Given this list of marker genes ZEB1, NUFIP2, CDY1, CCDC83 (NCBI Gene Id 220047), ACRV1, NLRP2B, RGS21, NDRG1, CCNK, MMP12, TSHZ2, FBRS, ZCCHC9, ERI1, PPM1E, OTUD7B, PCBP2, RBM25 (NCBI Gene Id 58517), DIO2, IPMK, FGD4, DOP1A, ZNF566, CYP7B1, AKT1S1, CDY1B, HSPA9, ZG16, LINGO2, HSD11B2, GOLGA7, MTMR4, FAM131A, FSD2, APOL6, PCGF5, PCBP1, AFF3, C16orf54, PAPOLG, KPNA4, MORF4L1, UNC45B, TMEM167A, PRLR, DNM3 (NCBI Gene Id 26052), KBTBD2, HSPH1, SMC4, MARCHF7, WDR55, CYP20A1, DCP1A, ZC3HAV1, ADGRF5, GREM2, PRR11, ANKS1A, EEF1E1, here is a description of the gene set: Genes predicted to be targets of miRBase v22 microRNA hsa-miR-6807-5p in miRDB v6.0 with MirTarget v4 prediction scores > 80 (high confidence targets). species: Homo sapiens Human Gene Set: MIR6807_5P from publication Chen Y, Wang X (PMID 31504780)